Given this list of marker genes HECTD2, MAPK8, NETO1, ERCC4, DSP, SLC16A7 (NCBI Gene Id 9194), ZNF772, EDIL3, USP22, FXYD4, TBC1D8B, HELQ, PDPK1, SAMD8, MITD1, TENM3, TRABD2B, KDM4B, FNDC3B, POLR3G, CLNS1A, UBA6, PDE6D, MID2, SFI1, RAB11A, DPP10, PDE4D, SERINC1 (serine incorporator 1), BPNT2, PPM1E (protein phosphatase, Mg2+/Mn2+ dependent 1E), CNKSR2, WDR33, ZBTB11, LRRC8B, ALDH18A1, ZNF567, ZBTB34, ST3GAL2, VPS4B (vacuolar protein sorting 4 homolog B), KLRC1, ACTC1, SGIP1, CHMP2B, KLHL4, RAP2B, SERTAD2, ARHGEF38, SOCS6, ADARB2, FMR1, FAM135A, TVP23A, MTRF1, PRKAA2, CDK1 (cyclin dependent kinase 1), CACNB2, KCTD9, NLGN1, KLF5, PHIP, SLC19A4P, GPSM2, ANK3, RRM2, PIK3CA, SIGLEC9, CCSER2, STAG1, SEPSECS, ERCC6, IGDCC4, RREB1, PRR16 (proline rich 16), C1QL3, NBEA, EPHA7 (EPH receptor A7), SIX3, MEIOC, RPS6KA6, PHF21B, RIMOC1, MAPRE2, KDM7A, CXXC4, KLHL7, PTPN4, MON2, DCAF10, LRRTM3, ZFP3, MAGEE2, PAK5, AS3MT, SLC25A21, ELF5, RCAN3, SPRED1, ANKUB1, BCHE, MDGA2, GRAMD1B, PKIB, ZFHX3, DDX59, NUP35, PRSS23, UHRF1, PUM2, GPR180, RPRD1A, TUBB2B, IGF2BP3 (NCBI Gene Id 10643), CLDN16, SCAI, ZNF396, IL17A, PLCB4, POLQ (DNA polymerase theta), SH2D1A, CNST, SLC9B1, ARMC1, QKI (NCBI Gene Id 9444), PKN2, USF3, VWDE, FAM133B, APAF1, RNF212, ARHGAP12, RUBCNL, KIF4B, SH3GL3, ARL1, DNAH7, RBFOX1, KIAA0930 (KIAA0930), GSKIP (GSK3B interacting protein), GNGT1, URI1, SLC10A2, GPM6B, CA2, INPP4A (NCBI Gene Id 3631), LSM6, ASB14, ARID4B, TNKS2, AMMECR1, CSMD3, ZNHIT6, PPM1B, AQP4, ETNK1, TBX3 (NCBI Gene Id 91834), LINC03103, SEC24B, TRIM24, MAP10, CCDC198, ZNF32, PLSCR1, CDK15, GAGE1, ACTN2, KBTBD3, ZNF326, ADAMTS3, EVI5, MCF2, KIF21A, CEP135, SNX2, SPIN4, E2F3 (NCBI Gene Id 1871), PRKAR2B, SNTB1, USP4, GRM6, ACOT2, FRZB (NCBI Gene Id 2487), GIGYF2, TLR4, JRKL, GPR34, NMBR, RALGPS2, UFM1, ST18, SREK1, DNAJB14, WEE1, RAB21, RNF20, RBM41 (RNA binding motif protein 41), ZNF621, MAP1B, CTNNA1, CTNNA3, BAZ2B, ADAM22 (ADAM metallopeptidase domain 22), AKR1D1, ZBTB6, SLC39A10, RCHY1, MED13L, DPY19L1, STON1, ASTN2, DDAH1, XRN1, MFN1, HACE1, ARHGEF12 (Rho guanine nucleotide exchange factor 12), AP1S2, STMN2, FRAS1, NR1D2, EMC8, STRBP, ATM, ACTR3, CFTR, GPR85, GALNT11, LRCH2, GOLPH3L, PICALM, IPO7, KIF26A, KIF23, TLR7, EIF4G1 (NCBI Gene Id 1981), APPBP2, UBE2D1, LIN28B, RABGGTB, ARMC8, COL11A1, LRRC7, FEM1C, SRSF1, VCPIP1, KIF4A, CCNJ, SFPQ, CTBP1, AKAP6 (A-kinase anchoring protein 6), RBBP5, PRKG1, HMGB1, SASS6, ROBO2, INO80D, GPRIN3, IQGAP2, LCORL, PLEKHA5, KHDRBS1, CCN3, CEP44, BUB3, ZBTB1 (zinc finger and BTB domain containing 1), CMKLR2, RAB18, ATP8A1, ZDHHC2, ABHD6, NR2C2, SON, PCMTD1, B4GALT6, BACH2, SLC30A6, MBNL3, ELAVL2, RPS6KA5, RASGRF1, here is a description of the gene set: Genes predicted to be targets of miRBase v22 microRNA hsa-miR-4760-3p in miRDB v6.0 with MirTarget v4 prediction scores > 80 (high confidence targets). Human Gene Set: MIR4760_3P from publication Chen Y, Wang X (PMID 31504780) species: Homo sapiens